The following is a description of a gene set: Human Gene Set: GOMF_POLY_PYRIMIDINE_TRACT_BINDING Binding to a stretch of pyrimidines (cytosine or uracil) in an RNA molecule. species: Homo sapiens, and this is the list of marker genes: RBM11, U2AF2, PABPC1, DAZAP1, HNRNPU, RBMS3, MSI1, PABPC1L2B, PABPC1L, HNRNPH1 (heterogeneous nuclear ribonucleoprotein H1), PNPT1, FMR1, PATL1, PABPC5, SSB, RBMS1, PABPC4L, MCRS1, IFIT5, PABPC3, ATXN1, PABPC1L2A, KHDRBS1, PTBP1, PABPC4, RBMS2 (RNA binding motif single stranded interacting protein 2), MSI2, DIS3L2, KHDRBS2, HNRNPC